Given this list of marker genes SLC2A3 (NCBI Gene Id 94827), PGK1, ENO1, IGF2, FLT1, PKM (NCBI Gene Id 8127), EDN1, EPO, CITED2, GAPDH, SERPINE1, BNIP3, ALDOA, VEGFA, SLC2A1, CA9, ADRA1B, HK2, HMOX1, IGFBP3, IGFBP1, CDKN1A, ADM, AK3, P4HA2, TGFB3, TF, TPI1, PFKL, CP, NOS2, IGFBP2, LDHA, ALDOC, TFRC, HK1, here is a description of the gene set: studied in species Homo sapiens from publication Semenza GL (PMID 11516994) Hypoxia-inducible factor 1 (HIF-1) activates transcription of genes encoding proteins that mediate adaptive responses to reduced oxygen availability. The HIF-1beta subunit is constitutively expressed, whereas the HIF-1alpha subunit is subject to ubiquitination and proteasomal degradation, a process that is inhibited under hypoxic conditions. Recent data indicate that HIF-1 plays major roles in the prevention of myocardial and cerebral ischemia and in the pathogenesis of pulmonary hypertension and cancer. Modulation of HIF-1 activity by genetic or pharmacological means could provide a novel therapeutic approach to these common causes of mortality. Human Gene Set: SEMENZA_HIF1_TARGETS Genes that are transcriptionally regulated by HIF1A.